The following is a description of a gene set: Human Gene Set: REACTOME_NONHOMOLOGOUS_END_JOINING_NHEJ species: Homo sapiens Nonhomologous End-Joining (NHEJ), and this is the list of marker genes: UBE2N, H3-4, H2BC15, RIF1, H4C15, NSD2 (NCBI Gene Id 7468), RNF8, H2BC7, PIAS4, H2BC14, H2BC12L, TP53BP1, H4C3, BRCA1, H4C11, KAT5, H2BC12, H4C9, H4C1, H2BC10, H2BC26, H2AX, MRE11, LIG4, HERC2, H2BC5, RAD50, H2BC8, H2BC9, TDP2, POLM, ATM, H2BC6, UIMC1, H2BC1, RNF168, H4C6, H2BC13, PRKDC, H4C16, UBE2V2, H4C12, BARD1, H4C2, H2BC21, DCLRE1C, BRCC3, H4C5, H4C13, BABAM1, H4C4, H2BC17, H4C8, PAXIP1, ABRAXAS1, NHEJ1, BABAM2, NBN, POLL, XRCC5, XRCC4, TDP1, MDC1 (NCBI Gene Id 9656), XRCC6, H2BC11, H4C14, H2BC4, H2BC3